Given this list of marker genes Tgfb1, Foxp3, Aire, Xkr8, Tgfbr2, Lyn, Ccr7, here is a description of the gene set: Tolerance induction directed at self antigens. species: Mus musculus Mouse Gene Set: GOBP_TOLERANCE_INDUCTION_TO_SELF_ANTIGEN